Given this list of marker genes CDC42BPA, PALLD, MYH11, COL4A1, ALDOB, DLC1, MAP3K5, RGS6, CACNA2D1, ACTA2, PDE3A, DGKG, ROCK1, PBX1, HPSE2, RBPMS, MYO1D, RERG, PTPRG, AKT3, CLMN, FRY, SORBS2, NTRK3, FBXL7, PDE1A, ZFHX3, ZEB1, FLNA, CACNB2, GRID2, TAGLN, COL4A2, AKAP6, PRKG1, NR2F2-AS1, SLCO3A1, EPS8, FER, IGFBP5, TPM1, SPARCL1, FCHSD2, ATP10A, FTX, TACC1, DYRK1A, SLIT3, AUTS2, PLPP1, INPP4B, DGKB, CACNA1C (calcium voltage-gated channel subunit alpha1 C), DUSP1, FOSB, NRXN3, ZFP36L1, MYLK, NEAT1, UBR3, COL18A1, ROCK2, MYH9, KCNAB1, HSPH1, EGR1, HSPA1B, AFF3 (NCBI Gene Id 3899), ACTN4, PPP1R12A, DMD, RCAN2, TBC1D1, WSB1, KIF13A, PAN3, JUN, CTNNA3, CBLB, MCAM, SSBP2, DNAJB1, ARID1B, TMTC1, MBNL1, EPAS1, DOCK4, MEIS2, NHS, FOS, CALD1, TNS1, CRIM1, LPP, AKAP12, BMPR2, SOX5, CDH13, CAMK2D, PIP5K1B, ARIH1, DST, DGKH, NBEAL1, PPP1R12B, LRCH1, VCL, ATF3 (NCBI Gene Id 467), ARHGAP6, MAML3, HIP1, EBF1 (EBF transcription factor 1), PDZRN4, MED13L, SIK3, TBX2, SDK1, ARID5B (NCBI Gene Id 84159), UBC, HSPA1A, UTRN, RBMS3, MSRB3, THSD4, ADGRL3, NR4A1, ZFP36, PTEN, RAPGEF2, ANKRD36, RASAL2, APBB2, PDLIM5, ADIRF, ITGA1, DSTN, ESYT2, TIMP3, LHFPL6, ZNF704, PAWR, DLG2, JUNB, SLC8A1 (NCBI Gene Id 6546), TJP1, ARHGEF7, PLCL1, TTC28, MEF2C, GPX3, A2M, KALRN, AKAP13 (A-kinase anchoring protein 13), GPC6, SYNPO2, here is a description of the gene set: from publication Lake BB, Chen S, Hoshi M, Plongthongkum N, Salamon D, Knoten A, Vijayan A, Venkatesh R, Kim EH, Gao D, Gaut J, Zhang K, Jain S (PMID 31249312) studied in species Homo sapiens Human Gene Set: LAKE_ADULT_KIDNEY_C27_VASCULAR_SMOOTH_MUSCLE_CELLS_AND_PERICYTES